Given this list of marker genes Pcdh15, Clrn2, Ankrd24, Atp2b2, Clic5, Myo3b, Whrn, Sod1, Sec24b, Myo7a, Lhfpl5, Tecta, Clrn1, Rest, Pdzd7, Scrib, Ripor2, Myo3a, Triobp, Tprn, Grxcr2, Grxcr1 (glutaredoxin, cysteine rich 1), Strc, Cdh23, Nherf1, Pls1, here is a description of the gene set: species: Mus musculus Mouse Gene Set: GOBP_AUDITORY_RECEPTOR_CELL_STEREOCILIUM_ORGANIZATION A process that is carried out at the cellular level which results in the assembly, arrangement of constituent parts, or disassembly of a stereocilium. A stereocilium is an actin-based protrusion from the apical surface of auditory hair cells.